The following is a description of a gene set: studied in species Homo sapiens Genes down-regulated in the temporal cortex samples from patients with major depressive disorder. from publication Aston C, Jiang L, Sokolov BP (PMID 15303102) Human Gene Set: ASTON_MAJOR_DEPRESSIVE_DISORDER_DN Major depressive disorder is one of the most common and devastating psychiatric disorders. To identify candidate mechanisms for major depressive disorder, we compared gene expression in the temporal cortex from 12 patients with major depressive disorder and 14 matched controls using Affymetrix HgU95A microarrays. Significant expression changes were revealed in families of genes involved in neurodevelopment, signal transduction and cell communication. Among these, the expression of genes related to oligodendrocyte function was significantly (P < 0.05, fold change > 1.4) decreased in patients with major depressive disorder. Eight of these genes encode structural components of myelin (CNP, MAG, MAL, MOG, MOBP, PMP22, PLLP, PLP1). Five other genes encode enzymes involved in the synthesis of myelin constituents (ASPA, UGT8), or are essential in regulation of myelin formation (ENPP2, EDG2, TF, KLK6). One gene, that is, SOX10, encodes a transcription factor regulating other myelination-related genes. OLIG2 is a transcription factor present exclusively in oligodendrocytes and oligodendrocyte precursors. Another gene, ERBB3, is involved in oligodendrocyte differentiation. In addition to myelination-related genes, there were significant changes in multiple genes involved in axonal growth/synaptic function. These findings suggest that major depressive disorder may be associated with changes in cell communication and signal transduction mechanisms that contribute to abnormalities in oligodendroglia and synaptic function. Taken together with other studies, these findings indicate that major depressive disorder may share common oligodendroglial abnormalities with schizophrenia and bipolar disorder., and this is the list of marker genes: RALA, KLK6, SLC31A2, AAK1, KIF1B, RNASE1, ABCA8, TAF11, CADM4, OLIG2, CDKN1C, TSPYL1, FAM53B, APOD, COPA, PLP1, DFFA, LILRA4, PLAGL2, NAPA, PDK2, ACSM3, COL16A1, CLDND1, PDE8A, GUSBP14, SLF2, LPAR1, RASGRF1, ERBB3, RNF19B, COL4A5, FGFR2, LDB3, SYNGR2, PPFIBP2, MAL, MTMR2 (NCBI Gene Id 8898), LAMP2, ARHGEF10, RBM8A, SEMA3C, BCAT1, MOBP, PSEN1, PLPBP (pyridoxal phosphate binding protein), PTP4A2, BBX, DYNC1LI2, CDK18, KLRC1, SOX10, SNX19, SCARB2, TMEM87A, UBE2A, ENOSF1, APLP1, UNC13A, SPOCK1, ASPA, TMEM63A, ENPP2, EPHA5, ABCA2, PSMD11, ZFP36L2, LINC00847, MAPT, DICER1, MAN2A1, LIPA, GABRB2, TRIO, TIAM1, NUP88, PWAR5 (NCBI Gene Id 8123), LITAF, FADS1, GPR37, ATM, PIK3R1, PCSK2, GOLGA2 (NCBI Gene Id 2801), SLC4A2, PDE6B, CNOT9, ZKSCAN1, KIF2A, EFS, MYO9B, LMO4, MAG, MAPK8, KIF13B, CAPN3, MOG, PRKCQ, P2RX7, NPIPB3, PPP2R3A, MYO1E, CNP, BRD2 (NCBI Gene Id 9803), WWP1, SORBS2, DPH2, TMC6, EVI2A, NPC1, VAMP3, PMP22, CDH19, PALM2AKAP2, LRP8, PTK2B, ST18, SYNJ2, MX1, CRYAB, CRYBG3, MCM7, UGT8, AMD1, CACNG3, SCAMP5, SS18, NTRK2, MDC1, NKX2-2, SNRPE, MYRF (myelin regulatory factor), PCBP2, FOLH1, BIN1, HSPA2, EP300, SRPK3, GLA, PRPF19, NFASC, FRMD4B, CAP2, TF, CDK8, CDC42EP1, TMBIM6, STIP1, SPOCK3, GPRC5B, PLLP, SRSF10, LIPE, JAM3, ADIPOR2, SF1, RDX, CYP19A1, CNTN2, HTR4, DDX11